The following is a description of a gene set: Human Gene Set: HAY_BONE_MARROW_ERYTHROBLAST species: Homo sapiens from publication Hay SB, Ferchen K, Chetal K, Grimes HL, Salomonis N (PMID 30243574), and this is the list of marker genes: POLR2I, BOP1, REXO2, PSMG3, BCS1L, FBXO7, DDB1, KMT5A, HIKESHI, TRAK2, NFIA, SMC6, PCNA, DIAPH3, FKBP4, ZW10, SNX22 (sorting nexin 22), CCNB1, APEX1, TOMM40, PSMD7, CPOX, SUV39H2, SPTLC2, PHB2, FEN1, SPA17, UQCRC1, TPRA1, DKC1, SLC25A3, PRXL2B, ARL6IP6, MRPL39, RFC2, RNF187, SERBP1, MRPL27, SMIM1, HBQ1, SNRNP70, SMC2, IDH2, YBX1, AASDHPPT, DAAM1, ORC1, DCAF11, PLEK2, MRPS18A, PSMC6, LMO2, NUDT4, STIP1, IFI27L1, THOC6, NDUFB3, EIF5A, GAR1, RILP, KIF20B, COA4, EIF2AK1, TXN2, USP15, CENPS, MCAT, GBGT1, ACAD9, CDCA2, FAM72D, TMEM141 (NCBI Gene Id 85014), TUBB6, NOP56, FARSA (phenylalanyl-tRNA synthetase subunit alpha), POLE3, ATP23, SLC29A1, HBS1L, METTL2A, ELOVL1, TUBAL3, ACHE, AQP1, YWHAH, CLTA, SNW1, SEC14L3, MRPL13, S100A3, ANAPC7, GCAT, MCM6, CENPE, UQCC2, ABCC5, PPP2R1B, WBP4, SOX6, GTF2F1, BUB1, ADAMTS3, TCEA1, ACAA2, TIMM17A, ATP5MF, WIPI2, COPB2, DNAJC8, NDUFAB1, HDAC3, FIS1, RPL22L1 (NCBI Gene Id 553116), CYB5A, YIPF6 (NCBI Gene Id 286451), CCDC124, TGS1, GRB10, TROAP (trophinin associated protein), RAD23B (NCBI Gene Id 5887), EIF4G1, STOML2, FAM114A2, HACD3, ERCC6L, NDUFA10, EME1, AK6, TRMT112, ATAD5, MAP2K3, EIF3J, EIF4EBP1, SLC4A1, POC1A, PFKM, EXOSC9, NPRL3, RIOK1, XRCC3, KCNH2, ALAS2, SNHG10, NECTIN1, ANKRD9, STK25 (serine/threonine kinase 25), DECR2, FXN, ARMC1, TBRG4, FANCA, PRMT6, EPRS1, UQCRQ, TXNDC9, RAN, SMC3, SNRPF, DCUN1D5, NADK2, MRPS16, POLR1G, MCM3, ESPN, SPTA1, HES6, TXNRD2, PFDN6, ILF2, PDHB, POP7, ALDH1A1, FOXRED1, MKKS, CCNE1, SYNCRIP, SRSF1, MMADHC (NCBI Gene Id 27249), MRM1, ORC2, ELAVL1, RPA1, NOP58, APOBEC3B, CETN3, GRWD1, STAM, NDUFA6, NMNAT3, ZMYND8, RPP30, RFWD3, LSM4, REXO5, HAUS2, UBAC1, CMAS, HEMGN, WDR4, A4GALT, ERI2, GPN3, SRPK1, MTCH2, SLC2A1, TIMM44, PRPF19, MRPL15, FADS2, CDC6, MRPS18B, SLC22A4, NDUFV3, RPA2, SEPTIN11, ARL9, HBA1, RAD23A, MRPL22, CDK2, AAAS, PTTG1, DPY30 (dpy-30 histone methyltransferase complex regulatory subunit), XRCC6, GINS3, METTL21A, EPCAM, PRKDC, PNPT1, POLD3, CRACD, PPAT, CDK1, HCCS (NCBI Gene Id 4307), PPA2, MNS1, DNAJC19, CD36, PAFAH1B3, HADH, MRPL47, EIF3I, BUB1B, GATB, NFS1, TFRC, TBC1D7, BSG, PLEKHH3, USP48, KLF1, ACSBG1, LINC01133 (long intergenic non-protein coding RNA 1133), UBE2T, MRPS34, MRPL35, RRP15, PTH2R, FAM83D, PTK2 (NCBI Gene Id 5747), KEAP1, NUP35, FANCD2, CYCS, HPDL, MTERF2 (NCBI Gene Id 80298), GINS1, C9orf40, DNAJC6 (DnaJ heat shock protein family (Hsp40) member C6), C6orf89, ZNF451, ERFE, MFHAS1, G3BP1, SNRNP25, MRPS28, VPS25, TFR2, WDR5, PSMB1, HDGF, CENPK, BYSL, STRIP2, RPS6KL1, GOT2, FUNDC2, PLK1, RPIA, RAD51C (RAD51 paralog C), PHETA2, PSMD1, RMDN3, HBG1, NCL, PRIM1, PSMD11, ANAPC11, PSMC2, RIPOR3, AGPAT5, BSG-AS1, PRELID2, METAP2, YPEL4, DPH2, RBBP4, NEK1, HSPA8, MRPS11, LAS1L, KLHDC8B, ISOC1 (NCBI Gene Id 51015), RBFA, NIBAN2, CCDC86, KIAA1586, PPIH, RANBP1, ENSG00000248161, VDAC3, PIR, KGD4, MRPL37, THOP1, ISCA2, NT5M, RRM2, FKBP3, ATP5PF, ABCE1, IFI27, TSPO2, MSH2, MRPL57, TIMM50, CCNA2, RFC4, AK1 (adenylate kinase 1), HPS1, SNRPA1, MACIR, MPP1, POLR3K, PCLAF, CCDC34, TUBB2A (tubulin beta 2A class IIa), MTX1, VCP, CNP, ENSG00000275527, NDUFS3, APEH, H1-3, ANKH, ZDHHC14, DDT, NDUFS8, NFIX, HSPBP1, ETFA, MRPL19, NDUFA9, HNRNPF, XRCC2, PSMB6, GFI1B, PTCD3, MRPL58, MALSU1, PRPS1, LARS1, IMP4, PPM1G, BCCIP, ECT2, BOLA3-DT, COMMD1, LAGE3, MCUR1, NOL7, HMGN5, TMOD1, CD58, PSMG1, DMC1, GCLC, DNAJA1, CDC16, CAT, TRIP13, YWHAE, ST6GALNAC4, ALAD, SLC2A4RG, FXYD3, PDCD4, AARS1, MRPL12, LRPPRC, NDUFA8, SHMT1, MRPS17, ANP32B, HDHD3, DNAJC15 (DnaJ heat shock protein family (Hsp40) member C15), RPF2, CHAC2, AGFG2, SYNGR1, LUC7L2, QTRT1, SLC25A39, HDDC3, TEX30, DPH6, GLRX, POLR2E, PHB1, ELOVL6, NDUFV2, ACKR1, RBM17, GFUS, SLC11A2, GSPT1, PTGES3, MIX23, PRDX2, POLE2, MKS1, CARM1, CCT3, ACSS1, EMC4, MRPL2, PSMA3, PSMB5, COPS5, YBX3 (Y-box binding protein 3), CD59, PCCB, RRP1, MAP2K2, SLC1A5, THOC7, PPME1, ESD, SLC30A6-DT (SLC30A6 divergent transcript), DGUOK-AS1, SLC9B2, ADD2, ENY2, CKAP5, MRPL36, TRMT10C, PPOX (protoporphyrinogen oxidase), MRPL50, KPNA3, PBK, SUPT16H, PRPS2, ARVCF, PPT2, FUT1, MRPS22, DPF3, GPT, COASY, STRADB, PMPCB, FARSB, KIF20A, SPAG5, PPIP5K2, TNS1, GYPB, EIF4H, STOM, NDUFAF3, U2SURP, CLCN4, EXOSC8, DPM2, DEXI, RPL7A, RFC5 (NCBI Gene Id 5985), SLC6A8 (solute carrier family 6 member 8), GMNN, PARVB, TMPRSS9, CRLS1, HAUS6, DRG1, DDX11, EIF1AY, FKBPL, PDCD2L, MTX2, SLC25A21, LRR1, TIMM23, FAM72C, EI24, MRPL17, PAK1IP1 (NCBI Gene Id 55003), PRPF40A, SNRPD1, NUP37, AIMP2, SPART, MSH6, E2F4, WDHD1, HBD, GYPC, ARV1, SNCA, SEC22C, NUTF2, DHFR, KATNBL1, ARPC1A, COQ9, SPDL1, POMP, CA3, SNX8, MTERF3, ALDH1B1, MRPL45, MIS18A, SSRP1, METTL1, PKP4, CPSF3, AK7, MPST, PHOSPHO1, NCAPH, CEP57L1, HAT1, TMEM14C, MRPL14, KCNJ12, ST13, ARHGEF12, DYNC1LI1, MIPEP, SLBP, RUVBL2, RNF40, ILF3, STEAP3, ATP5F1B, MDN1, RHCE (NCBI Gene Id 652552), CFAP298, MRPL21, UTP18, ACOT13, HIGD1A, UQCRFS1, NDUFA2, MRPS15, GTF3C6, COA1, NELFCD, DMTN, CCNB2, HLTF, THOC3, MRPS18C, ATP1B2, ETFB, AKR1C3, HPF1, MELK, ADISSP, SCOC, RANBP10, MRPL28, MYH10, TIMM13, GFOD2, CNKSR3, TUBA1C, VCF2, CCDC14, TCERG1, PSMA4, HBZ, SPECC1 (NCBI Gene Id 92521), MRPL11, SH3GLB2, MTFR1, TCP1, ELOC, CCT7, TEDC2, ABCF2, TSFM, KIF23, AURKA, RAD54L, TIMM21, DEPDC1B, RCCD1, NDUFV1, AFG3L2, HSF1, DLD, DDX1, TBPL1, ZNF788P, PLPP4, MICU2, CR1L, CA1, TRAP1, MRPL18, ESCO2, PSMD6, BANF1, LXN, PSMB7, TSPAN5, RNF5, IGF2BP2, SREBF1 (sterol regulatory element binding transcription factor 1), SPESP1, TUBB4B, CBX3, UBXN10, RPA3, AUNIP, PES1, NDUFB9, FAM178B, GAS2L3, RCC1, CDK4, ORC6, N6AMT1, DNAJA4, SASS6, DNAJC9, KIF18A, POMGNT2, CEP152, POLDIP2, FN3KRP, KLHL18, MRPL20, VRK2, TIMM8A, TFDP1, PC, ERH, POLR3H, BLVRA, DCAF6, TMA16, MRPL51, NUP62CL, DNAJC11, RLIG1, ACADS, TTK, NUDC, ENG, CCDC47, CKAP2, PCMT1, PISD, GLRX5, NAE1, IFT52, AMD1, GNL2, NOC3L, KREMEN1, FH, ZNF367, PRDX3, FAH, FAM110D (NCBI Gene Id 79927), UMPS (uridine monophosphate synthetase), EIF5B, MORN2, CMBL, ATP5F1A, PA2G4, C19orf48P, TESC, KLHDC3, ERMAP, MRPS9, ECI2, SF3B6, VBP1, POLR2F, HSD3B7, SNRPD3, TSPAN17, DYRK3, ATP5MC1, PYCR3, VANGL1, C17orf58, IL17RE, SAR1B, AKR1C1, RPLP0, LIN9, NEDD4L, HSDL2, TAL1, MCM10, PRDX6, CTSE, DIMT1, PKLR, DECR1, AIFM1 (NCBI Gene Id 9131), TBC1D23, NFYB, CCDC138, RFC1, DLEU1, EIF2S1, VARS1, PTBP1, TUBG1, CAPRIN2, SELENBP1, PSMC1, FDPS, CD82, GET3, HAGH, RFK, METTL13, AHSP, PNP, BAG1, AP2A1, MPDU1, TANGO2, ANK1, OIP5, NAA50, FN3K, PRC1, TXNRD1, PSMD9, ANKLE1, ICAM4, TRMT5, CENPH, COX5A, PPIL1, DEPDC1, SLC37A4, SPTB, IFTAP, ATG3, SLX9, CALM3, HEBP1, OGFOD2, PHF5A, SFXN4, FHDC1, CCDC169, RIPOR1, SLC25A38, WDR12, GTF2F2, EIF4E, SIGMAR1 (NCBI Gene Id 80768), CSE1L, LTV1, MLLT3, LINC02772, MCM2, C1D, PRMT3, MCM4, GCLM, NUP93, CDC27, RUVBL1, SNRPG, MMAB, VRK1, FECH, CHEK2, LSM5, BRCA2, CCDC15, IMPDH2 (inosine monophosphate dehydrogenase 2), PDAP1, NOP16, PLRG1, UROS, ATIC, GINS2, EPHB4, RFXAP, DTL, TIMMDC1, TAC3, RBX1, LSM3, UBE2K, RALBP1, PAGE2B, USP14, C1orf198, NME4, GMPS, FANCI, EPOR, KCNN4, SPHK1 (sphingosine kinase 1), COL18A1, CDCA3, CDC7, COMMD3, BCL2L12, MTFR2, CCT2, CSTF2, SLC22A16, CDT1 (chromatin licensing and DNA replication factor 1), PRKAB1, PARPBP, POLR2H, IFRD2, HMGA1, NIPSNAP3A, MRPL3, RAB3IL1, SLC44A4, PSMD8, PSMD12, HTRA2, MPC2, EIF2S2, HINT2, BABAM1, SLC43A3, NEK2, GLRX3, RARS1, ZFYVE21, OSBP2 (oxysterol binding protein 2), SPC24, TK1, AP2B1, MRPL4, NCAPG (non-SMC condensin I complex subunit G), UBTF, SLC25A15, HSPH1, RDX (radixin), PXMP4, HOOK1, SLC16A9, MRPL49, DOLPP1, AURKAIP1, CDCA4, ALDH4A1, CHAF1A, UROD, BOLA3 (bolA family member 3), TPRKB, GAD1, GYPA, CCT5, NAT10, RPL26L1, TST, GATA1, NAP1L4, OAT, SLC39A3 (solute carrier family 39 member 3), MRPS2, THEM6, MRPL1, RHD (NCBI Gene Id 6007), XK, POLD2, SMS, RCL1, HNRNPAB, KRT13, SDHA, PRKAR2B, SLC25A37, SPTBN2, REPS2, PLEKHJ1, PSMD3, DTYMK, SCCPDH, POLQ, SRI, PIP5K1B, TMEM86B, RTCB, CCT4, MICALL2, TTC8, H1-0, IK, SLC43A1, TOP1, ING2, NARF, RNASEH2A, EXOSC7, PIGW, HBA2, TPGS2, RNF123, NOP10, HSP90AB1, ZNRD2, JPT2, SLIRP, WIPF3, TARS1, ATP5MC3, BRCA1, GRPEL1, AMMECR1, SAMM50, ORC4, B3GALNT1, SSB, ACAT1, HARS1, COA7, XRCC5 (NCBI Gene Id 7520), TLCD4, TGM2, POLR2K, DHRS13, EIF1B, RPL8, MRM2, FAHD1, MAGOHB, FAM210B, MRPL16, DYNLL1, MTHFD1, MGAT3, ARHGEF39, DLGAP5, CENPW, ATP7B, UBXN8, KIF26A, RHAG, RNASEH2C, MIR4435-2HG, TRUB2, HBB, DNMT1 (NCBI Gene Id 1786), METTL5, RPL3L, HPRT1, SNRPB, MYT1, PUS7, SNRNP40, HSP90AA1, EPDR1, BAZ1A, ZWILCH, SLC7A1, C17orf99, RRM1 (ribonucleotide reductase catalytic subunit M1), HBM, HSPA9, CDKN3 (NCBI Gene Id 1033), CLTC, PYCR1 (pyrroline-5-carboxylate reductase 1), LDB1 (LIM domain binding 1), KIF9, ACTL6A, ARMC8, ARL2, CAPRIN1, DYNC2I2, ATP5IF1, ACADVL, CSNK2A1, DUT, REC8, YEATS4, NCAPD3, EPS15-AS1, EIF3A, CDC45, CHID1, KIF4A, IMMT, HMMR, ENOSF1, HBG2, MRPS7, EXO1, NARS1, SSX2IP, ST6GALNAC1, TXNL1, NCS1, NOP14, RRP7A, ATP5PB, ALDH18A1, PSMC4, PSMA2, UQCR10, PITHD1, HSPE1, SNRPE, LPCAT3, SEC14L4, CPSF4 (cleavage and polyadenylation specific factor 4), NBAS, ANLN, CACYBP, AHSA1, ART4, SLC30A9, SKIC8, MCM5, C16orf95, DPCD, HSPD1, PLS1, CCT6A, SGTA, DSCC1, ARHGAP11A, MYL4, APEX2, ATPAF1, MFAP1, RAB13, ZNF273, RIDA, PRSS23-AS1, TMEM14B, BCAM, RFC3, FAM13A, MACROD1, RFESD, NDUFB6 (NADH:ubiquinone oxidoreductase subunit B6), ATP6V1C1 (NCBI Gene Id 528), CENPU, AP2M1, TTLL12, CHCHD1, NASP, PSMD2, ERI1, SOD1, KBTBD12 (kelch repeat and BTB domain containing 12), ENSG00000189316, ATAD3A, MBOAT2, SRP72, MRPL42, TRIM10, PIGQ, KHSRP, MARVELD2, NUDT1, LRRCC1, SUMO3, NCAPG2, TP53BP2, GUCD1, TAF9, AMT, WRN, EPB42, SLC10A4, EXOSC3, CYTOR, CA2, MOSPD1, CAST, NIF3L1, PGRMC2, NSMCE2 (NCBI Gene Id 286053), PAQR9, SLC39A8, MED8, C8orf88, GYPE, SLC38A5, TMEM14A, NANP, NDUFAF8, CENPP, SLC48A1, CBY1, NDUFS5, BAG2, MCM7, DHX15, EEF1E1, NCEH1, LRWD1, SSBP1, BRIX1, DDI2, TBL3, TMX2, ARHGAP23, ABCB10, ZNF620, SLC25A10, CA8, CHEK1, MINPP1, PSMB2, UCK2, CBR1, B9D1, ECH1, HMBS, VPS29, SLC2A4, RAB23, TIMM10, NDUFC1, NUP85, GART, RMDN1, CCT8 (NCBI Gene Id 9888), CISD2, WAPL, PSMA5, MRTO4, CLN6, GEMIN2, PPP1R8, NPL, MRPL46, LRRC59, SLC22A23, MGST3, SUGT1, SKA1 (spindle and kinetochore associated complex subunit 1), PKMYT1, GADD45GIP1, FBH1 (NCBI Gene Id 84893), CDC25A, ERI3, GPATCH4, CRISP2, TSR1, CENPX, TMEM237, POLA1, SLC6A9, HSPA4, POLD1, COMMD4, LSM2, MRPS10, AIDA, DSN1, LBR, PMM1, HK1, LINC00570, EIF2B3, RHOBTB3, ENSG00000260592 (novel transcript, antisense to TMC5), EXOSC2, SMIM10, HADHA, CHCHD3, IARS1, CIT, TIMM8B, UCHL5, UCHL3, MED25, TNXB, ASF1A, SNRPC, PSMF1, LCA5, ZDHHC3, CTNNAL1, EBNA1BP2 (NCBI Gene Id 10969), RECQL4, DHODH, MRPS31, RNF182, HDAC2, MECR, KIF2C, COQ3, ADSL, DUSP21, BCAP29, NDUFS1, KEL, YWHAG, ISOC2, CYC1, GTPBP4, SNRPA, PTRH2, COPS3, ROGDI, VPS9D1-AS1, CDC42BPA, PDHA1, SPATA33, PSMD14, RMND5B, SPRR2F, GHITM, PSMC3, NOLC1, PLK4, UQCC3 (ubiquinol-cytochrome c reductase complex assembly factor 3), HSD17B4, APOL4, PLA2G12A, ASH2L, PRMT5, PNPLA4, ICA1, STAU1, MFSD2B, SRSF2, CDC20 (NCBI Gene Id 991), BLVRB, CHPT1, PAICS, LRP11, RAD50, ICMT, DPM1, CCDC28B, PRKAR1B, CLPB, RIF1, FHL2, SMARCA5, CENPL, HSBP1L1 (heat shock factor binding protein 1 like 1), KNSTRN, MRPL34, TLN2, NDUFAF4, CKS2, GARS1